The following is a description of a gene set: studied in species Homo sapiens Salmonella SifA to microtubule plus-end directed transport. Pathway ID: N01298. Pathway type: Pathogen. Pathway class: nt06125 Membrane trafficking (bacteria). Pathway Definition from KEGG: SifA -> PLEKHM2 == (KIF5+KLC) == (TUBA+TUBB) Human Gene Set: KEGG_MEDICUS_PATHOGEN_SALMONELLA_SIFA_TO_MICROTUBULE_PLUS_END_DIRECTED_TRANSPORT, and this is the list of marker genes: KLC1, TUBA1C, TUBB2A, KLC2, TUBB8, TUBA8 (tubulin alpha 8), TUBA3E, KIF5C, TUBA3C, KLC4, KIF5B, TUBB4B, TUBA3D, PLEKHM2, TUBB4A, TUBB2B, TUBB1, TUBA1A, KLC3, TUBB6, KIF5A, TUBB, TUBA1B, TUBB3, TUBA4A